Given this list of marker genes ABI1, ACTB, ARPC5, CYTH4, ARF6 (NCBI Gene Id 63379), WASF2, PIK3CD, ARPC4, ARF1, WASF1, ARPC5L, ARPC1A, CYFIP1, NCKAP1, CYTH1, CYFIP2, ACTG1, ACTR3, ARPC1B, ACTR2, CYTH2, PIK3CB, ARPC2, CYTH3, NCKAP1L, ARPC3, BRK1, WASF3, PIK3CA, here is a description of the gene set: studied in species Homo sapiens Shigella IpgD to ARNO-ARF-ACTB_G signaling pathway. Pathway ID: N01067. Pathway type: Pathogen. Pathway class: nt06135 Cytoskeletal regulation (viruses and bacteria). Human Gene Set: KEGG_MEDICUS_PATHOGEN_SHIGELLA_IPGD_TO_ARNO_ARF_ACTB_G_SIGNALING_PATHWAY Pathway Definition from KEGG: IpgD -> PI(5)P -> PI3K -> PIP3 -> ARNO -> ARF6 -> ARF1 -> (WASF+ABI1+HSPC300+CYFIP+NCKAP1) -> ARP2/3 -> (ACTB,ACTG1)